The following is a description of a gene set: studied in species Homo sapiens Human Gene Set: MIR532_5P Genes predicted to be targets of miRBase v22 microRNA hsa-miR-532-5p in miRDB v6.0 with MirTarget v4 prediction scores > 80 (high confidence targets). from publication Chen Y, Wang X (PMID 31504780), and this is the list of marker genes: KRAS, TRHDE, CIBAR1, AFG2B, EPHA4, PDS5B, PCDHB10, RCOR1, SLC5A3, PWWP2A, ATP8A1, COLCA1, SPATS2, ADAM22, LIN9, BHLHE41, DENND6A, BICDL1, TMED7 (NCBI Gene Id 51014), SVOPL, ATP13A3, HYCC2, GCC2, SLC25A46, GPATCH2L, NDP, SNX16, EPC1, CDO1, NCF2, AHSA2P, ZRANB3, XPO4, TTC14, PCGF3, AASS, CNTN5, TAB3, SESTD1, CCNG1, MDFIC, COG5, NR5A2, SPIRE1, SRSF12, RGPD5, SKIL, RGPD8, CPEB3, CYCS, SEPTIN14, ARID2, PTPRJ, FRS2, SMARCC1, TAP1, IRS2, SI, RAVER2, FOXP1, SUCLG2, CXCL1, RAB11A, CXCL2, RASSF5, RAP2A, RABIF, LCA5, MINDY2, VPS13C, NR1I2, RGPD4, PARD3, TUBD1, BICC1, SUCLA2, FHIP2A, XRCC5, HECTD2, RGPD6